Given this list of marker genes PHOX2B, H4C6, ZNF446, FOXK1, KLF4, ISX, RORB, RAD51AP1, ERCC6, ESRRG, SRF, ADNP2, DRGX, ARID4A, FOXG1, NUCKS1, ARID1A, H2BW1, TIPIN, STAT2, KDM4B, ELF2, IRF8, E2F7, POLE3, THAP7, H2AC18, HDX, KDM5C, H4C14, HEYL, PARP1, H3C14, NAP1L2, H4C13, SMCR8, NFIX (nuclear factor I X), H3C12, RHOXF1, RBL1 (RB transcriptional corepressor like 1), H4C15, SIX6, H2BC6, TSPY8, ZFP42, SF3B1, E2F2, HPF1, NFIA, H3-3A, SALL4, DLX4, HSF4, BPTF, TCF12, NKX6-2, ELF5, CEBPG, CDX4, DNTT, SMARCAD1, KLF11, CDX1, H4C11, ATOH7, HDAC1, PRM1, HSFX1, ZNF487, INTS8, PAWR, ANAPC7, RXRA, MESP2, HNRNPC, USF1, USP22, PELP1, CREB3, SLF1, HOXB13, H2AC13, FOS, PBX4, HMX3, FOXL1, RELB, CENPS, H2AC20, CHRAC1, TNKS1BP1, ARRB1, ZFHX2, BCL11A, PPP4R2, ACTG1, NFE2L1, NSD3, EBF2, NR0B2, RFX5, HDAC4, PHF20L1, ATF6B, NOBOX, HOMEZ, CHD7, EZH1, PGR, TBX10, GATA5, CHD4, MORC3, OTX2 (NCBI Gene Id 5015), BRD3, CDK2AP2, ESR1, SIX2, TRNP1, AR, PITX2, UBE2B, NKX1-1, CDKN2A, NOP53, H2BK1, PBRM1, ETV4, MSL2, TRIM66, IRF5, VAX1, CDK2AP1, NFE2L3, CHMP7, TBX4, CHD8, NR3C2, FOXP3, BBX, SMARCA2, SPDEF (SAM pointed domain containing ETS transcription factor), HES2, UHRF1, CENPX, AFF4 (NCBI Gene Id 27125), FAAP100, VPS72, PINK1, NCOA2, AKIRIN1, INO80B, NKX2-8, H1-7, TAF9, ZHX1, SMAD4, EPAS1, H3C13, H4C8, DLX5, HP1BP3, HMBOX1, TEAD3, XRCC1, HOXB6, EGR3, SKIC8, LUZP1, MCM7, ARK2N, H1-10, HIF3A, TGM2, ILK, E2F4, RBBP7, LHX6, HAND1, MTBP, DMRT3, KDM5D (lysine demethylase 5D), MEF2B, KAT5, EXOSC3, H2BC10, MLXIPL, H2AC6, BRDT, SUPT20H, NMNAT1, POTEJ, PAX6, EZH2, WDR76, HEY1, H1-8, THRB, ARMC5, EMX1, PLK1, HOXA10, ASCL4, JADE2, MAFK, FOXB1 (forkhead box B1), KLF17, DMRT2, BASP1, HOXA1, MYF5, MSGN1, PPP2R1A, SET, TP63, HMGN4, TEAD1, MECP2, H2BC5 (H2B clustered histone 5), HNRNPD, AHRR, FIZ1, PRRX1, VSX2, MSL3, TGIF2, H2AC4, NAP1L1, RNF2, JARID2, SREBF1, KMT5A, RB1, NHLH1, ETV7, DMRTB1, EN1, SHLD3, PAX2, H1-3, MSL1, BMAL2, MORF4L2, TSPY4, SS18L1, THRA, HOXC9, PPP4R3B, OVOL3, ORC3, YY2, TAF1, HESX1, FEV, ATXN7, H2BC19P, FANCF (NCBI Gene Id 2188), OSR1, CPSF6, FOXC1, PIAS4, PARPBP, HOXD10, H1-6, TSPY1, ZNF711, DDX23, XIST, RUNX3, ETS1, ORC2, MAX, H3-4, RORA, TFDP2, H2AC7, PCNA, POU6F1, FANCC, SOX30, TET1, HES7, SRCAP, KLF2, WDR82, FOSL2, SOX7, ELF3, NR1D2, ATF6, CENPB, NEUROG2, PPP1R10, CHD2, YY1AP1, CLOCK, BCL7A, NPM2, KANSL3, ZBTB43, H2BC11, MGA, NSD2, SLF2, MKX, NEUROD1 (NCBI Gene Id 7853), KLF15, H2AC25, NKX2-5, SOX3, KAT7, CCND2, TSPYL6, H3-5, GATA6, NFRKB, BHLHA15, FOXJ3, CBX2, NR1H4, ANP32E, CITED2, TFDP1, FOSB, TRPS1, IRF9, HMX2, HMX1, MEIS2, H2BC9, SUV39H1, SOX15, RELA, RRP1B, H4C3, MXD1 (MAX dimerization protein 1), NR4A2, PARK7, MTA1, TPRX1, NFE2, TGIF1, GBX2, GMEB2, NFYB, LBX2, MYOCD, TAF5L, LHX9, BAZ2A, PAX3, DMBX1, H3C7, HOXA5, LMX1B, TBX22, GLYR1 (NCBI Gene Id 84656), MSC, RARG, ASF1A, HCFC1 (NCBI Gene Id 8267), CHMP2A, SOX10, FOXC2, POTEKP, SF3B5, CSNK2A1, IRX3, DLX1 (distal-less homeobox 1), GSX1, ONECUT1, SMAD2, TBP, NPAS1, SOX13, SRPK2, BRD1, EMX2, CALCOCO1, SOX14, TGIF2LY, SRPK1, ZNF827, EP300 (NCBI Gene Id 2033), IRX2, LDB1, PIAS2, GRHL2, SPI1, ZBTB32, DDB2, STAT1, MACROH2A1, PBX2, SOX6, DBP (NCBI Gene Id 1628), TASOR, H3-3B, TCF3, ZBTB8B, BANF1, BATF2, H2BC14, ZBED4, HOXC10, PRMT5, CAMTA2, EBF4, THAP5, EBF3, FANCE, SIRT6, HOPX, H1-9P, CREM, EN2, SMAD3, FOXN2, OIP5, NOTO, MAF, H2BC1, HELT, KLF3, MYC, NKX6-1, FOXA2, FOXO1, ZNF705A, HMGN5, DPF2, ERF, FOXD3, GSC2, KLF16, JUNB, PCGF2, DNMT3L, TP73, SP7, RHOXF2B, IRF6, BRD2, DNMT1, DLX2, HSF2, HOXC5, APTX, H2BW2, GSX2, EHMT2, DNMT3A, STAG3, COPS9, MMS22L, H3C4, RBL2, BRD7, H3Y2, BRMS1L, LEUTX, CUX1, TAF4, FOXN4, PROX1, CSNK2A2 (NCBI Gene Id 650690), HOXB3, MIXL1, HOXD12 (NCBI Gene Id 3238), STAT3, ALX4, CREB3L4, JDP2, SOX9, PAX9 (NCBI Gene Id 5083), DLX6 (NCBI Gene Id 1750), ATF5, CDK4, TSPYL2, DDIT3, EVX1, KDM1A, NKX2-6, SUZ12, RNF40, H2AX, UXT, TFAP2D, NIPBL, H2AC17, STAT6, TBX2, HES4, RFX4, H2AJ, RAD21, SP1, E2F1, FOXD1, FANCG, SP9, BMI1, POTEF, KDM1B (NCBI Gene Id 254751), KAT14 (lysine acetyltransferase 14), KDM3B, TADA2A, TBX3, ESRRA, H1-1, DPRX, SOX18, HOXC4, NPAS3, MACROH2A2, MNX1, ING5, MSX1, NEUROG3, H3-7, MTA2, VDR, ZNF740, POLE4, NPAS4, DVL3, HOXB1, PLK2, LMX1A, WDR5, ZFHX3, PIAS3, DMRTC1, H2AC15, HMGXB4, ZC3H8, FOXQ1, ASCL5, PHF12, TSPYL1, HOXA2, FOXK2 (NCBI Gene Id 84213), POGZ, NR4A1, BICRAL, NR2F6, TADA3, ESRRB, ANKRD31, ZBED3, FANK1, CHD1, ZBTB34, HOXB2, GATA1, MED1 (NCBI Gene Id 9327), MRGBP, ELK3, PRAME, NR2C2, NRIP1, EXOSC5, NR2C1, UBR2, KANSL1L, H2AC19, MAFF, NFATC1, SATB1, TCF7, SETSIP, TFEB, NKX2-3, NFAT5 (nuclear factor of activated T cells 5), GSC, IST1, TADA2B, PADI2, BARX1, FOXD4L6, INCENP, FANCD2, SOX21, KAT6B, SP4, TCF15, ICE1, KLHDC3, SS18, SPRTN (SprT-like N-terminal domain), TAF9B, SOX12, MAFA, ZNF385A, RBMX, KDM4E, ZBED1, TBR1, FOXD4 (NCBI Gene Id 2298), SIRT2 (sirtuin 2), PHC2, TFCP2L1, TSPY2, KLF13, ARNT2, SETD5, SHLD2, HES5, HLF, ATF2, ZBTB18, SIX1, FANCM, SLX4, H2AB3, RUVBL1, CREB3L3, MNT, ACTL6A, CHD6, JUN, FERD3L, IRF2, AEBP2, NKX2-4, ZFHX4, DPF1, HOXC8, IRX5, TCF21, H1-0, CREBBP, CBX3, PHF14, POU1F1, H1-2 (H1.2 linker histone, cluster member), FOXN3, ZBTB33, SF3B3, KLF10, HNF4G, FOXL2, TCP1, OBI1, POU4F2, SKIC3, ALX3, TAF7, ZMIZ2, HSFX3, CCAR2, SUPT20HL1, SP2, ING3, ARID2, H4C9, DBF4B, SHOX2, FBH1 (F-box DNA helicase 1), TBXT, MORF4L1, RUVBL2, TAL2, HNRNPAB, SINHCAF, FOXE3, HNF1B, GMEB1, SALL1, ING2, DEK, RARB, TBX21, ORC5, DFFB, HTRA2, NCOR1, UBA1, PAX7, GATA4, BRPF1, TAL1, NR5A1, TAF2, BATF3, NSMF, ICE2, PPP4C, ELF1, PTF1A, GCM1, NR1H3, LOXL2, FLYWCH1, MEF2A, FANCI, SMARCD2, HOXC13, SOHLH2, TADA1, TCF7L1, CBX1, ACTB, TLX1 (T cell leukemia homeobox 1), HDAC3, KAT6A, FOXI1, FIGLA, KMT5C, SREBF2, RFX3, KDM4F, FOXM1, KLF14, HEY2, ENC1, FOXF2, BRMS1, DDX21, LEMD2, SIM2, DMRTA2, NKX1-2, DMRTC2, LYL1, TEAD2, JUND, BACH2, EGR4, TSPY9, RBPJL, RAD51, ERG, NFYA, NR4A3, ZFY, HOXA3 (NCBI Gene Id 3200), SIN3B, STAT5B, TFAP4, SMARCD1, H3Y1, ETV6, NKX3-1, IPO4, RPA2, POU2F1, NANOG, HIF1A, SATB2, NFKB2, COPS5, TSPY3, PRM3, NEUROD4, FOXD4L1, H3C2, RIF1, SIM1, BCL7C, ESR2, H2AZ1, SMAD9, HNRNPDL, BHLHE22, SMAD7, PRM2, CDX2, SCX, H2BC4, SDR16C5, ELK1, ELK4, NCOR2, HSF1, H2AZ2, BHLHA9, IRF3, DBX1, PDS5A, MIS18A, KLF6, PROP1, PIAS1, FOXO4, STAT5A, ESCO2, FAAP24, TFAP2E, TBX19, ZNF174, KDM4C, MAP3K7, HMGA1, SMARCA1, PPARA, RFX7, HOXC6, MBTD1, SETD3, MXD3, ETV3, NHLH2, TRIM33, FOXP4, SIN3A, CEBPB, DUXA, MAEL (maelstrom spermatogenic transposon silencer), NEDD4, ACTL8, YEATS4, TFAP2B, TIMELESS, PAX8, POU2F2, SMAD5, ALX1, ESCO1, NR3C1, FOXP1, TBX18, REL, ETS2, H2BC18, PAX4, BNC2, MEOX2, EME1, H4C7, UBE2A, CEBPD, IRF1, E2F8, HOXB4, RNF20, ZEB2, SOX11, NELFE, INO80D, UHRF2, SPIN1, H2AL3, TARDBP, CREBZF, SAP130, TBX1, MITF (melanocyte inducing transcription factor), TGIF2LX, AHCTF1, HOXD13, HIC1, CECR2, FAM111B, SFR1, KDM5B, KAT2B, HMGB2, ADNP, FOXI2, BACH1, ZBED6, TP53, HSFY1, MBD3, HR, ZHX2 (zinc fingers and homeoboxes 2), H3C10, H1-5, RFX2, BRPF3, H3C11, RRP8, CENPC, FOXN1, KAT2A, NR5A2, MSH6, BHLHE23, TBX15, SMAD6, SIX3, TBX5, TSHZ3, TLX3, NFXL1, IRX6, BARHL1, TSHZ2, ATRX, SMARCC1, BMAL1, BCL11B, SFPQ, TFEC, HLCS (holocarboxylase synthetase), NR1H2, ARGFX, MEF2C, ATF1, H2AC11, ID2, MAD2L2, MYT1 (NCBI Gene Id 4661), HOXB9, POLR1A, POTEE, HOXB5, FOXJ1, NR2E1, ESX1, MXD4, ASCL2, HHEX, H2BC13, EVX2, MEIS1, NKX6-3, VRTN, PROX2, SNAI2, PHC1, UBP1, PITX1, UPF1 (UPF1 RNA helicase and ATPase), ZNF580, H2AC1, RAX2, THAP11, RUNX2, BARHL2, NACC2, H2BC26, FOXD4L4, KANSL1, HELLS, HOXD3, ELF4, TOP2B, KDM4A, MLX, BSX, BAZ2B, FANCA, H2AB2, INTS6, STAG1, KLF9, CSNK2B, EPC1, FOXE1, SMARCB1, MEAF6, FOXB2, TSHZ1, LRWD1, ALKBH1, RFX6, DR1, LHX8, HOXD1, TFPT, CHAF1A, NFE2L2, SRY, EXOSC10, SOHLH1, ZMYND8, NFATC4, FOXD2, DSCC1, FOXO6, FOXA3, VENTX, ARID1B, FANCB, H2BC3, TFE3, POU4F3, CSRNP3, ZEB1, HES3, FOXJ2, MPHOSPH8, MCM2, PRRX2, ZNF396, MYBBP1A, ATOH1, DMRT1, ANKRD2, WAPL, EIF3E, FOXD4L5, NPAS2, MEIS3, RCC1, NKX2-2, SIRT7, ATF7, H2BC12L, SGF29, ASF1B, KIF22, HBP1, GABPA, MYCN, KMT2E (lysine methyltransferase 2E (inactive)), POU6F2, NFATC3, GATAD2B, HNRNPL, IKZF1, PHF10, RBPJ, SOX1, SUPT20HL2 (SUPT20H like 2), SWI5, PBX1, TONSL, NCR1, ASCL1, MEN1 (NCBI Gene Id 4221), SP5, POU5F2, SIRT1, EHMT1, BHLHE40, MUC1, HAT1, L3MBTL1, NEUROG1, SETD1A, ACTL6B, TAF6, CSRNP2, PSIP1, RHNO1, HOXA7, DMAP1, PPARGC1A, DPF3, BORCS8-MEF2B, BRD4, FOXR2, ZBTB22, H4C16, H3C1, OLIG1, UCHL5, ARID4B, YEATS2, IRF4 (NCBI Gene Id 4592), PHOX2A, ZBTB5, ACTBL2, RHOXF2, TSPYL5 (NCBI Gene Id 85453), MAGED1, CREBL2, PKNOX1, LHX3, NSD1, UNCX, HMGA2, H2AC8, TSPYL4, RARA, GCM2, PPARD, SMAD1, SUV39H2, SMARCA5, CBX5, PDS5B, H3C3, SMARCA4, HMGN2, TMPO, FOXP2, JMJD1C, H2AC12, SIX5, EED, TNP1, HSFY2, RAN (NCBI Gene Id 87046), PRKDC, TEAD4, TNP2 (transition protein 2), SPIB, BUD31, CENPA, BHLHE41, TAF6L, ZNF618, CIC, H2BC7, MESP1 (NCBI Gene Id 55897), CAPN2, TCFL5, PLCB1, LHX4, POTEI (NCBI Gene Id 653269), ATXN7L3, XPC, DHX9, H3C8, SOX2, EOMES, FAM111A, OTX1, MSX2, MSL3B, NR0B1, MXI1, H3C15, HMGN1, ASCL3, SUDS3, CBX7, PAX1, HOXD8, CHD3, LHX2, SUPT7L, CRX, ZHX3, E2F5 (NCBI Gene Id 1875), SCRT2, USF2, HES6, SHPRH, RFX8, H2AC21, IRX1, ACTR6, EGR1, ELL, GRHL1, ST18, ONECUT2, DDX11, H4C12, NR6A1, RSF1, ZC3H6, AKAP8L, BRD8, POU5F1B, TCF23, ZGPAT, H2BC21, SSRP1, BARX2, MORC2, CENPF, SUPT3H, AHR, SMC3, ZBTB37 (NCBI Gene Id 84614), LEF1, RXRB, MEF2D, SOX5, RXRG, H4C4, DMRTC1B, HNF4A, SAP30, HOXC11, NFKB1, GBX1, POU3F1, H4C2, NAP1L3, ISL2, ISL1, GRHL3, CEBPA, WDR43, HSFX2, PPARG, FANCL, KLF1, TAF12, EP400, H2AP, MCRS1, TRRAP, SHLD1, ZBTB46, ENY2, CEBPE, VRK1 (NCBI Gene Id 7443), PRDM10, ING1 (inhibitor of growth family member 1), ZMIZ1, NASP, BAZ1B, CUX2, ZFPM2, KDM4D, NAP1L4, ONECUT3, NR1D1, SP3 (Sp3 transcription factor), H3C6, TEF, SP6 (Sp6 transcription factor), MAFB, LBX1, STAG2, ETV5, CTNNB1, VSX1 (NCBI Gene Id 8198), H2BC12, GATA3, LHX1, CASZ1, SUPT16H, TCF4, CHD5, GATAD2A, ETV1, RBBP4, USP44, NEUROD6, PDX1, ANKRD17, NFATC2, FAM47E, NCOA1, CBX6, ZFX, ARNT, ACTR8, NRL, YY1, CREB3L1, EXOSC4, HOXB7, CBX8, H2AB1, TWIST1, NR1I2, NFX1, CSRNP1, OLIG3, INO80, NCAPD3, TBX6, TFDP3, DFFA, WBP2, HES1, TFCP2, H4C5, RING1, H2BC15, SOX8, JAK2, IRX4, MYO1C (NCBI Gene Id 4641), HMGN3, FOXR1, RORC, TRIM28, AKIRIN2, HOXD4, TSPY10, HDAC2, UBE2U, POU2F3, MBIP, TAF5, POU3F3, SMARCD3, MYOG, EBF1, BEND3, DEAF1, HOXA9, KAT8, POLA1, H4C1, HOXD11, HAND2, HIRA, ZZZ3, UBR5, TFAP2A, CHAF1B (NCBI Gene Id 8208), HOXA6, TBX20, RUNX1, DMRTA1, THAP1, ING4, TFAP2C, TAF10, INO80E, SOX4, NKX2-1, PAAF1, PAX5, ACTR5, EHF, JADE3, ZSCAN1, SMC2, H2BC17, EGR2, DBX2, PBXIP1, ZNHIT1 (NCBI Gene Id 10467), FOSL1, CDCA5, ARX, CTR9, KLF7, BATF, ATF3, POU3F4, BRD9, CHEK1, JADE1, SPIC, ZBED2, BICRA, STAT4, KLF12, SPIN4, H2BC8, E2F3, MBD2, CREB5, TCF7L2, ATF4, TOX4, VAX2, PPP2CA, PRKAA1, H1-4, MYT1L, FOXH1, FOXO3, POU3F2, FOXS1, HOXA4, MLXIP (MLX interacting protein), MYCL, INO80C, MYOD1, HOXA13, NFIB, E2F6, BCL7B, MTA3, NEUROD2 (NCBI Gene Id 4761), MEOX1, SMARCC2, DDX6, H2BN1, PHF20, MAU2, HNF1A, HOXD9, NKX3-2 (NCBI Gene Id 579), OTP, OGT, PITX3, SAP30L, ATOH8, NCOA3, MYF6, TRIM24, USP3, H2AC16, RAX, HLX, HNRNPK, RFX1, FER, SIX4, NFIC, IRF7, BCAS3, CREB1, POU4F1, KLF8, NFIL3, FOXD4L3, FAAP20, OLIG2, KDM5A, TLX2, LHX5, KANSL2, C17orf49, PBX3, FOXA1, NUFIP1, SOX17, SHOX, DLX3, HOXB8, SNAI1, KDM3A (NCBI Gene Id 55818), NR1I3, FOXF1, EPC2, SP8, FLI1, CFDP1, ZFPM1, KLF5, NFYC, SPHK2, SMARCE1, BAZ1A, CREB3L2, here is a description of the gene set: Human Gene Set: GOCC_CHROMATIN The ordered and organized complex of DNA, protein, and sometimes RNA, that forms the chromosome. species: Homo sapiens